Given this list of marker genes FECH, ENSG00000303681, RPL17-C18orf32, CXXC1, ATP5MC1P6, DYNAPP3, PSTPIP2, NEDD4L, MRPL37P1, ARK2N, LINC01539, SKOR2, POLI, PIGN, IER3IP1, ELOA3BP, HDHD2, GAD3P, ZBTB7C-AS2, CDH20, ENSG00000289168, RPL29P32, RNU6-116P, ME2, RNU4-17P, SNORD58B, MRPS5P4, MBD2 (NCBI Gene Id 8932), CTIF, RSL24D1P9, SMAD7, WDR7, RNA5SP457, MIR4527, RELCH, SERPINB13, DYNAP, RNA5SP459, MYO5B, ATP5F1A, MTCO2P2, LIPG, DYNAPP1, POLR3GP2 (NCBI Gene Id 649392), RNA5SP456, ENSG00000267732, RNU1-46P, MIR4744, RAX, OACYLP, ENSG00000267401, SRSF10P1, RN7SL342P, LOXHD1, RNU6-1278P, BOD1L2, CCDC68, LINC01929, ENSG00000299730, MIR4527HG, SERPINB7, ELOA3DP, ENSG00000267762, ARK2C, PHLPP1, TNFRSF11A, NARS1, SERPINB11, RPL17P46, RN7SL705P, MAP1LC3P, LINC01905, RPL30P14, RPS3AP49, ZNF532, ONECUT2, GRP, RPS8P3, RNU6-708P, PRR13P4, PIAS2, HNRNPA3P16, SRP72P1, SCARNA17, SNHG22, PLEKHB2P1, MALT1-AS1, RNA5SP458, ENSG00000301416, SNORA73, LINC03111, MIR122HG, RNU6-142P, ST8SIA5, ATP8B1-AS1, CTBP2P3, KDSR-DT, MIR1539, WDR7-OT1, SERPINB12, CPLX4, ENSG00000199713, C18orf54 (NCBI Gene Id 162681), VN1R76P, SERPINB3, ENSG00000310339, DYM-AS1, SNRPGP2, ENSG00000302008, LINC-ROR, STARD6, ADAD1P2, ENSG00000295596, ELAC1, SMUG1P1, VPS4B, LINC01897 (NCBI Gene Id 124904311), ELOA3P, RN7SL310P, TXNL1, SS18L2P2, TCF4, SNORD58A, ACTBP9, RPIAP1, LINC01926, ENSG00000267764, LINC01919 (long intergenic non-protein coding RNA 1919), ENSG00000267743, ZBTB7C, RNU6-737P, RAB27B, LMAN1, SNORD58C, LINC01630, ZCCHC2, MEX3C (mex-3 RNA binding family member C), MIR4529, ENSG00000267284, SERPINB2, RNF152, LINC01544, SMAD4, TCF4-AS2, EPG5, ACAA2, KDSR, MIR4743, MRO, ST8SIA3, LINC02837, SEC11C, ALPK2, MC4R, RNU6-219P, SNORA108, TPMTP1, MAPK4, RNU6-567P, DYNAPP2, RPL9P31, SINHCAFP2, RNU2-69P, DCC, CFAP53, BCL2, SMAD2, RN7SKP26, MALT1, RNY4P37, ENTR1P1, LINC02565, HAUS1 (HAUS augmin like complex subunit 1), MIR4320 (microRNA 4320), MIR122, MIR4528, SERPINB4, ZBTB7C-AS1, MIR3591, SERPINB5, RPS26P54, GLUD1P4, RSL24D1P11, NFE2L3P1, RPL21P126, RPL17P44, LINC01416, RPLP0P11, ELOA2, RNU6-1131P (RNA, U6 small nuclear 1131, pseudogene), LINC01415, CUPIN1P, CCBE1, LINC01917, PMAIP1, RPL17, LINC03110, ATP8B1, ELOA3CP, C18orf32, RPSAP57, DYM, TCF4-AS1, HMGN1P31, MBD1, RNU6-742P, RPLP0P12, ST8SIA5-DT, KATNAL2, HMGN1P30, SKA1, SNORA37, here is a description of the gene set: studied in species Homo sapiens Human Gene Set: chr18q21